The following is a description of a gene set: Mouse Gene Set: REACTOME_REGULATION_OF_PYRUVATE_METABOLISM Regulation of pyruvate metabolism studied in species Mus musculus, and this is the list of marker genes: Pdk2, Ranbp9 (NCBI Gene Id 56705, RAN binding protein 9), Maea, Ldha, Pdha1, Rps27a, Armc8, Rmnd5b, Gid4, Pdk3, Pdhb, Gid8, Rmnd5a, Pdk4, Ubb, Pdha2, Pdp1, Me1, Uba52rt, Ubc, Nek1, Wdr26, Pdpr, Gstz1, Pgam5, Pdk1, Uba52, Pkm, Sirt4, Dlat, Pdp2 (NCBI Gene Id 71628), Dld, Mkln1, Pdhx